Given this list of marker genes Gabrb3, Cep112, Erbb4, Nlgn3, Gabra2, Git1, Lhfpl4, Glra1, Bsn, Maf1, Igsf21, Gphn, Iqsec3, Igsf9b, Gabrg2, Nptn, Clcn3, Nlgn2, Igsf9, Gad2, Rims2, Rims1, Syt11, Dtnb, Nrxn1, Slc32a1, Gad1, Pclo, here is a description of the gene set: Mouse Gene Set: GOCC_INHIBITORY_SYNAPSE species: Mus musculus A synapse in which an action potential in the presynaptic cell reduces the probability of an action potential occurring in the postsynaptic cell.